The following is a description of a gene set: The process in which the neural tube is divided into specific regions along the rostrocaudal axis. Mouse Gene Set: GOBP_ROSTROCAUDAL_NEURAL_TUBE_PATTERNING species: Mus musculus, and this is the list of marker genes: Shh, Bmi1, Atp6ap2, Ssbp3, Hes1, Wnt1, Pax6, Fgf8, Lrp6 (low density lipoprotein receptor-related protein 6), Sox17, Hes3, Kdm2b, Gbx2, En1